The following is a description of a gene set: from publication McBryan J, Howlin J, Kenny PA, Shioda T, Martin F (PMID 17486082) Expression microarray analysis identified over genes regulated during puberty in the mouse mammary gland. Most prominent were genes whose expression increased in parallel with pubertal development and remained high thereafter. Members of the Wnt, transforming growth factor-beta and oestrogen-signalling pathways were significantly overrepresented. Comparison to expression data from CITED1 knockout mice identified a subset of oestrogen-responsive genes displaying altered expression in the absence of CITED1. Included in this subset are stanniocalcin2 (Stc2) and amphiregulin (Areg). Chromatin immunoprecipitation revealed that ERalpha binds to oestrogen response elements in both the Stc2 and Areg genes in the mammary gland during puberty. Additionally, CITED1 and ERalpha localize to the same epithelial cells of the pubertal mammary gland, supporting a role for interaction of these two proteins during normal development. In a human breast cancer data set, expression of Stc2, Areg and CITED1 parallel that of ERalpha. Similar to ERalpha, CITED1 expression correlates with good outcome in breast cancer, implying that potential maintenance of the ERalpha-CITED1 co-regulated signalling pathway in breast tumours can indicate good prognosis. studied in species Mus musculus Genes down-regulated during pubertal mammary gland development between week 5 and 6. Human Gene Set: MCBRYAN_PUBERTAL_BREAST_5_6WK_DN, and this is the list of marker genes: VAPB, TPR, MAP4K2, AKAP9, IL6R, SFPQ, LASP1, OGT, EIF3C, ADISSP, RESF1, DNMT3A (NCBI Gene Id 1788), LPGAT1, CALD1, PANK1, THRAP3, XIST, CYTH1, CSNK2A1, FSCN1, COX8BP, AKT2, ZEB2, CUX1, RBM5, SREK1, FUBP1, MAPK8, STAT5B, MEF2C, SLC2A4, RAB5C, SLC25A10, SNTB2, SLC2A5, MAPK14 (mitogen-activated protein kinase 14), PRRX1 (paired related homeobox 1), GPD1, BLTP2, PANK3, NFIX, FTO, HEMK1, SLC38A10, CYGB, ZBTB20, ARHGEF2, CPD, IP6K1, GYS2 (glycogen synthase 2), ACACA, NFATC3, RBBP4, ITSN2, NRIP1, PTEN, NORAD, SMARCA4, EGLN1, EIF4EBP2 (NCBI Gene Id 1979), SEC61A1, FUS, PRPF19, FZD4, NFIC, DAPK1, PPP6R3, CCND2, TYR, YKT6, FIGN, SOX9, CNOT3, LALBA, EHD2, TMEM79, SRPK2, TAOK1, NFIB, ACLY, TBL1X, ZBTB7B, HSD17B11, CLEC3B, HDLBP, CHD4, MALAT1, YWHAG, CAVIN1, TNS1, BRD4, ATXN7L3B, SECISBP2L, RAD23A, RUNX1, SMC6, RPL37A, DDX6, NEAT1, FGG, ZFHX3, DBP, KEAP1, RGS5, SDC4, EIF4G1, WNK1, DPYSL3, GBP4, IL6ST, OGFR (NCBI Gene Id 51783), QPCTL, ATP8A1, KCNB1, PPP2R5B, KDM5A, NDST1, ATP1A3, CSPG4, WASL, SPPL2A, AIRN (NCBI Gene Id 100271873), UBD, CRIM1, SIRPA, PDAP1, EBF3, QKI, PCYT1A, DHX36, PURB, MBTPS1